Given this list of marker genes ARSA, PSAP, LYST, ABCA1, COA8, here is a description of the gene set: Progressive peripheral neuropathy species: Homo sapiens Human Gene Set: HP_PROGRESSIVE_PERIPHERAL_NEUROPATHY